The following is a description of a gene set: from publication Yosef N, Shalek AK, Gaublomme JT, Jin H, Lee Y, Awasthi A, Wu C, Karwacz K, Xiao S, Jorgolli M, Gennert D, Satija R, Shakya A, Lu DY, Trombetta JJ, Pillai MR, Ratcliffe PJ, Coleman ML, Bix M, Tantin D, Park H, Kuchroo VK, Regev A (PMID 23467089) species: Homo sapiens Human Gene Set: GSE43955_TH0_VS_TGFB_IL6_IL23_TH17_ACT_CD4_TCELL_52H_UP Despite their enormous importance, the molecular circuits that control the differentiation of Th17 cells remain largely unknown. Recent studies have reconstructed regulatory networks in mammalian cells, but have focused on short-term responses and relied on perturbation approaches that cannot be applied to primary T cells. Here, we develop a systematic strategy – combining transcriptional profiling at high temporal resolution, novel computational algorithms, and innovative nanowire-based tools for performing gene perturbations in primary T cells – to derive and experimentally validate a temporal model of the dynamic regulatory network that controls Th17 differentiation. The network is arranged into two self-reinforcing and mutually antagonistic modules that either suppress or promote Th17 differentiation. The two modules contain 12 novel regulators with no previous implication in Th17 differentiation, which may be essential to maintain the appropriate balance of Th17 and other CD4+ T cell subsets. Overall, our study identifies and validates 39 regulatory factors that are embedded within a comprehensive temporal network and identifies novel drug targets and organizational principles for the differentiation of Th17 cells. Genes up-regulated in CD4 T helper cells (52h): Th0 versus Th17 treated with TGFB1, IL6 and IL-23., and this is the list of marker genes: LRRC59, FGF4, DCTN3, FOXL1, PDIA5, PLAT, EDEM1, RTTN, MYPOP (NCBI Gene Id 339344), DAZ2, API5, ABCB4, CXCL3, SYP, ACSL1, TOP1, IFIT2, FOXM1, TMX1, P4HA2, TOM1, MEOX1, CTBP2, TOB1, DDHD1, IFIT3, NCK2, SCHIP1, KGD4, PCGF5, SPEG, JAG2, MYL1, FAM20C, CISH, CXCR5, CCL13, PCID2, OSBPL11, RMND5A, SEMA4D, ADAR, AMPD3, RBBP7, ATAD1, MKRN1, LMO4 (LIM domain only 4), KCNA3, CCL22, ZBTB14, FNDC3A, IPO5, ADIPOR2, KCNJ1, MEF2A, FSTL3, TMEM205, MAK16, EIF4H, E2F8, CCNG2, NUDT4, UBE2G1, ZNF239, DBI, ISG20, DAXX, CMPK1, TBC1D1, ANXA2, SETD4, IL18, HOXD9, KMT5C, HSPH1, GJA8, FRMD6, ESD, NCDN, CYB5R4, BMAL1, CACNB3, SPTAN1, PLXND1, MAN2A1, GANAB, TSKU, ZP1, NLK, GLUL, HSP90AB1, PELI1, NUS1, TBC1D23, SLC26A2, PDLIM7 (PDZ and LIM domain 7), GLRX, PLAUR, COX6B2, IL1A, REPS1, GJB1, PGK2, BOD1L1, EEF1AKMT1, RNF11, CAPN5, HESX1, HIC1, PPP1CB, MARK2, CYP7B1, MFAP4, MTHFR, IRF9 (interferon regulatory factor 9), WDR82, HSPA1B, NDFIP2, STK10, KRT81, ITGA4, ANTXR2, ARID2, PEA15, TCEA1 (NCBI Gene Id 7865), RNF208, SEMA6D, IL12A, MYOG, RNASET2, FGFR1OP2, RDX, HSPA1A, PITPNC1, NHP2, ACSF3, SQSTM1 (sequestosome 1), CCNI, PNP, PRKG2, TFRC, RGN, MFSD14B, CASC3, CDH16, CORO1A, SLC12A5, C2CD2, PRKCD, MYO5B, ELK1, CRCT1, CS, VEGFC, CDC45, RNF103, CSF1, EIF2AK2, EXOC8, PTCH1, C3AR1, SLC3A2, EGR2, ACP2, PTX3, ST3GAL5, GGPS1, UIMC1, SRCIN1, NR5A2 (nuclear receptor subfamily 5 group A member 2), GOLPH3, PKP4, CHD4, HCLS1, NSUN2, CH25H, LDLR, RHPN1, SULT2B1, TAGLN2, AXIN2, PPP1R21, IRF7, NCF1, MAP4K3, ATP6V1B2, F8, RDH11, CAPZA3, MFHAS1, INTS14, EMP3, CPXM1, S1PR3, COL18A1, TRAFD1, LYRM2, MAPK14, H2BC5, AMZ2